The following is a description of a gene set: from publication Chen Y, Wang X (PMID 31504780) Genes predicted to be targets of miRBase v22 microRNA mmu_miR_3971 in miRDB v6.0 with MirTarget v4 prediction scores > 80 (high confidence targets). species: Mus musculus Mouse Gene Set: MIR_3971, and this is the list of marker genes: Kmt2a, Ppp4r3a, Zfp626, Rnf170 (ring finger protein 170), Elavl2, Ghr, Reep5, Phlpp1, Arel1, Fam199x, Srgap3, Bahcc1, Xrcc5, Rbfox1, Pik3r1, Hus1, Trp53inp1, Ptpn9, Otud7b, Slc12a2, Rock2, Rgs7bp, Tcf20, Slc22a23, Prrg3, Lhfpl1, Sh3bp5, Crls1, Pnpla3, Ehf, Lpp, Yme1l1, Chd8, Rcbtb2 (regulator of chromosome condensation (RCC1) and BTB (POZ) domain containing protein 2), Zfp943, Nek1, Trpc5, Itsn2, Ttyh3, Nf1, Ilvbl, Basp1, Adgrl2, Cpne3, Ncoa3, Dcx, Tnfrsf12a, F13a1, 1700034J05Rik, Mgll, Ubap1, Ppp3r1, Kpna1, Tor1aip2, Tra2a, Kcnd3, Hbb-bt, BC051665, Glipr1l2 (NCBI Gene Id 67537), Fam185a, Efcab6, Gusb, Sdc1, Zfp52, Galnt1, Vash1, Nkd1, Rassf1, Tmem167b, Haghl, Nufip2, Zscan12, Gab2 (NCBI Gene Id 14389)